Given this list of marker genes MIR27B, MYLIP, TREM2, MIR144, MIR27A, ITGAV, ITGB3, MIR185, APOC2, NR1H4, MIR302A, MIR133A1, PCSK9, MIR96, FGF21, LDLRAP1, MIR33B, MIR17, LDLR, MIR199A1, GPIHBP1, MIR148A, MIR223, LIPG, IL19, KHSRP, APOC1, ANXA2, CNPY2, APOC3, GPLD1, HNRNPK, ABCC8, MIR128-1, CSK, MIR33A, LRPAP1, MIR379, here is a description of the gene set: species: Homo sapiens Human Gene Set: GOBP_REGULATION_OF_LIPOPROTEIN_PARTICLE_CLEARANCE Any process that modulates the rate, frequency, or extent of lipoprotein particle clearance. Lipoprotein particle clearance is the process in which a lipoprotein particle is removed from the blood via receptor-mediated endocytosis and its constituent parts degraded.